The following is a description of a gene set: A recurrent form of sinusitis. Human Gene Set: HP_RECURRENT_SINUSITIS studied in species Homo sapiens Recurrent sinusitis, and this is the list of marker genes: RSPH4A, COL5A2, PSMB8, SPAG1, C4B, GAS2L2, USB1, ZMYND10 (zinc finger MYND-type containing 10), TMCO1, DNAH5, LRBA, NFKBIA, DNAAF2, CCDC65, NEK10, RSPH1, FCGR3A, NME8, ALMS1 (NCBI Gene Id 7840), SASH3, TBX1, NCF4, MAGT1, STK4, SPI1, BTK, IL17RA, ICOSLG, IL21R, IVNS1ABP, DNAAF1, PIK3CD, CD19, NFKB1, TNFRSF9, NME5, ADA2, COL5A1, RNF168, CFAP298, MCIDAS, IKBKB, MGP, ZNF341, ODAD2, DNAAF6, ICOS (NCBI Gene Id 29851), BRWD1, DNAI2, PRKCD, ACP5, SEC61A1, IRF2BP2, CFAP74, RAC2, NFKB2, DNAAF5, UNC119, STXBP2, WAS, TBK1, DNAAF4, MDM4, DNAAF11, SH3KBP1, TNFRSF13B, HYDIN, DNAJB13, IGHM, STK36, CR2, IKBKG, TNFRSF13C, CFI, ODAD1, DOCK8